The following is a description of a gene set: species: Homo sapiens Abnormality of thumb phalanx A structural anomaly of one or more phalanges of the thumb. Human Gene Set: HP_ABNORMALITY_OF_THUMB_PHALANX, and this is the list of marker genes: EED, NSUN2, KCNN3, RLIM, XYLT1, TAF6, SATB2, UBE2T, GDF5, TWIST1, SOX9, SHH, TBX5, MAN2C1, RPS7, RPL31, RPL11, H3-3B, SMC3 (NCBI Gene Id 9126), GATA1, FANCF, ERCC4, INTU, NUP107, KNSTRN, RPL35, SLC26A2, RPS28, HEATR3, RPL5 (NCBI Gene Id 90045), RPS19, OFD1, PPP2R3C, NIPBL, RPL8 (ribosomal protein L8), DVL3, PTEN, NAA10, EXOSC2, MSX2, TP63, POGZ, BPNT2, KCTD1, FZD2, MEGF8, ACTG1, NXN, RERE, SLX4, RBM8A, HOXA13, GATA4, VPS35L (VPS35 endosomal protein sorting factor like), GPC4, RPS29, RPL15, BICRA, CNOT1, RPS17, LMBR1, LAMA5, TBC1D24, MAD2L2, HPGD, XRCC2, PCNT, MED12, ERI1, OTUD6B, CILK1, MAP3K7 (NCBI Gene Id 6885), PRKD1, FANCG, ADNP, CHST3, FIG4, BRCA2, MEIS2, INPPL1 (inositol polyphosphate phosphatase like 1), FLNB, COL2A1, HNRNPR, PACS1, RTL1, SHMT2, PUF60, B3GAT3, TRPM3, NSD1, SF3B2, GJA5, SUZ12, PSMD12, PAH, ACAN, RPS20, GJA8, MAFB, BPTF, USP9X, PIGF, CHSY1, SRCAP, ALG9, H3-3A, FANCA, DLX5, RAB23, NOG, FGFR1, PYCR2, ACTB, FGF10, SALL1, WNT5A, RPS15A, CREBBP, ALX4, RPL9, RAD51C, BMPR1A, RPS27, RPL26, DVL1, FGF9, CHN1, RFWD3, EZH2, KCNH1, RPL18, GLI3, RPL35A, DNM1L, FANCC, BMP2, PTCH1 (patched 1), RAD21, SIAH1, NONO, LIG4, BRCA1, BRD4, FGFR2, EP300, VAC14, PIK3CD, KIF7, RAD51, TRIO, HDAC8, GNAS, PALB2, BRIP1, BMPR1B, ZNF668, SMO, HOXD13, CWF19L1, SMOC1, ACVR1, SF3B4, BCOR, PQBP1, PIGB, RPL27, DHX30, TSR2, FANCB, FGFR3, DLK1, B3GALT6, PCDHGC4, FANCD2, PRKG2, SNIP1, SMC1A, G6PC3, FANCM, RPS24, ATP6V1B2, DACT1, MEG3, FLNA, CBFB, IHH, SALL4, UBAP2L, ROR2, ROBO1, GLI1, IFT56, RPS10, RPS26, ESCO2, ADA2, SUMF1, FANCE, SETBP1, FANCL, FANCI, CANT1, GPC3